Given this list of marker genes OSBPL5, ING2, CAPG, ZFYVE19, CLVS2, ADAP2, GAB2, TWF1, ATP13A2, ZCCHC2, OGT, STAM2, BTK, JPH2, SNX32, RUFY4, WDFY1, PITPNA, SNX17, SNX31, KCNJ3 (NCBI Gene Id 3760), PLCD1, TIRAP, DENND1C, PLA2G4A, PITPNB, PITPNM1, NCF1C, GSDMC, SYT1, ITPR1, RUBCNL, ITPR2, RNF34, SNX7, RCSD1, CGAS, VPS36, SYT9, SLC9A3, RACGAP1, FES, RPS6KC1, PLEKHA4, DAPP1 (NCBI Gene Id 27071), SLC9A1, SNX6, PLEKHN1, PLEKHB2, SNX3, DENND1A, WDPCP, ZFYVE28, GGA2, ATG2B, RLBP1, MITD1, KRIT1, VEPH1, SYT10, BBS5, ACTN2, PLD1, TOM1L1, SNX18 (sorting nexin 18), ARHGAP33, ESYT1, ZFYVE9, SNX29, ARFIP1, SNX25, DEFB4A, KCNQ1, TOM1L2, WIPI2, FCGR3B, PIRT, FLII, HS1BP3 (NCBI Gene Id 64342), SDCBP2, HIP1R, PLEKHF1, FUZ, MYO1G (NCBI Gene Id 64005), C8orf44-SGK3, GSN, CHMP3, APPL2, SNX19, GSDMA, FUNDC2, EXOC7, SDCBP, PIK3C2B, FCHSD2, INTU, TTPA, DNM1, RAG2, SAP30L, MAPT, LAPTM4B, SNX33, HCN1, ANXA2, BLTP2, SNX20, SNX24, SNX8, PXDC1, AVIL, TPCN2, FCHO2, COMMD1, RBSN, GOLPH3L, FRMPD2, SNX21, LANCL2, C2CD2L (C2CD2 like), ANXA8, DAB2IP, SYTL2, TRPM3, OSBPL2, ESYT3, MARK1, MYO1E, TOM1, GOLPH3, SBF2, VIL1, EPB41 (NCBI Gene Id 2035), PLD2, PARD3, GGA1, SCIN, DPEP1, AIDA, ATG2A, CCDC88A, SNX12, OBSCN, ARAP2, HGS (hepatocyte growth factor-regulated tyrosine kinase substrate), WDFY3, WIPI1, GSDMD, GRB7, PHF12, SNX1, PLEK2, MTM1, EEA1, MCF2L, PHLDA2, PIK3C2G (phosphatidylinositol-4-phosphate 3-kinase catalytic subunit type 2 gamma), SNX15, FGD2, DNM2, SH3PXD2B, PIGU, ZCCHC14, PASK, ZFYVE26, GSDME, WDR45B, PITPNM2, NRGN, GBF1, PLCB1, ADAP1, NLRP3, AMER2, NCF4, GGA3, SYT5, SNX30, SNAP91, SNX22, AKT1, TWF2, ARHGAP9, FRMPD4, PLEKHF2, FZD7, PIGT, CEACAM5, KIF16B, SVIL, PLCZ1, EXOC1, ULBP2, CLVS1, PLA2G4E, GRAMD2A, RAB35, PFN2, VILL, STAM, SYT7, SNX10, ARHGAP32 (NCBI Gene Id 9743), IQGAP2, OSBPL8, NCF1B, CFL1, IQGAP1, SNX4, NCF1 (neutrophil cytosolic factor 1), PXK (NCBI Gene Id 54899), SNX9, PLEKHA5, ARAP1, TULP1, WASHC2C, LDLRAP1, KCNJ1, SNX16, SEPTIN12, SH3YL1, TULP3, PHLDA3, WDR45, AMER1, SNX11, PIGK, WASHC2A, SNX27, GAP43, TLN1, PLEKHA8, ALOX15, CERT1, NISCH, TPCN1, GSDMB, MYO10, AMER3, ANKFY1, THY1, DOK7, PLEKHA3, APPL1, SESTD1, FERMT2, PHLDA1, SNX14, RUBCN, SNX5, TECPR1, MREG, ARFIP2, SCARB1, TNFAIP8L3, DENND1B, OSBP, PIK3C2A, ZFYVE16, ESYT2, KCNH1, KCNJ2, SH3PXD2A, BCAS3, NOXO1, MTSS2, SNX2, GPAA1, TTPAL, VPS13B, PITPNC1, PICALM, PFN1, RPH3A, ITPR3, HIP1, NUMA1, EXOC8, MYO1B, PARD3B, SNX13, TRPV1, CYTH3 (NCBI Gene Id 9265), ARAP3, ZFYVE1, MAPKAP1, SGK3, here is a description of the gene set: species: Homo sapiens Binding to an inositol-containing glycerophospholipid, i.e. phosphatidylinositol (PtdIns) and its phosphorylated derivatives. Human Gene Set: GOMF_PHOSPHATIDYLINOSITOL_BINDING